Given this list of marker genes ABCB11, SLC29A2, ABCC3, ABCC2, ATRAID, ABCA3, ABCC4, SLC29A1, SLC47A1, SLC28A3, ATP8B1, ABCC5 (ATP binding cassette subfamily C member 5), TMEM30A, ABCA8, SLC28A2, SLC37A3, SLC19A1, here is a description of the gene set: Human Gene Set: GOBP_XENOBIOTIC_TRANSMEMBRANE_TRANSPORT species: Homo sapiens The process in which a xenobiotic, a compound foreign to the organism exposed to it, is transported across a membrane. It may be synthesized by another organism (like ampicilin) or it can be a synthetic chemical.